Given this list of marker genes Nmnat1, Spi1, Klf7, Pou4f2, Lmna, Parp1, here is a description of the gene set: Any process that stops, prevents or reduces the frequency, rate or extent of adipose tissue development. studied in species Mus musculus Mouse Gene Set: GOBP_NEGATIVE_REGULATION_OF_ADIPOSE_TISSUE_DEVELOPMENT